The following is a description of a gene set: part of: Co-stimulation by CD28 CD28-mediated PI3K signaling plays a crucial role in augmenting T cell activation and survival. Phosphoinositide 3-kinases (PI3Ks) are lipid kinases that can be activated downstream of various receptors, including the T-cell receptor (TCR), co-stimulatory receptors like CD28, and cytokine or chemokine receptors. The role of PI3K signaling differs depending on the upstream receptor involved. CD28, specifically, contains a YMNM consensus motif in its cytoplasmic tail, which serves as a binding site for the p85 regulatory subunit of PI3K. <br>When CD28 is engaged, it promotes the recruitment of PI3K, complementing PI3K activation downstream of the TCR. This recruitment triggers the conversion of phosphatidylinositol (4,5)-bisphosphate (PIP2) to phosphatidylinositol (3,4,5)-trisphosphate (PIP3) at the plasma membrane, which serves as a docking site for multiple signaling proteins. Among these, the guanine nucleotide exchange factor VAV and the serine/threonine kinase AKT (also known as protein kinase B, PKB) are key mediators of CD28-induced costimulatory signals. PI3K activation through CD28 promotes cytokine transcription (e.g., IL-2), T cell survival via anti-apoptotic pathways, cell cycle progression, and metabolic changes necessary for T cell growth (Riha and Rudd. 2010, Miller et al. 2009, Han et al. 2012). Reactome Pathway: CD28 dependent PI3K/Akt signaling species: Homo sapiens, and this is the list of marker genes: PIK3R6, PIK3R1, FYN, RICTOR, PIK3R2, PDPK1, THEM4, M, PIK3CD, TRIB3, PRR5, PIK3R3, AKT2, MAP3K8, MTOR, AKT1, CD80, PIK3CG, CD86, CD28 (CD28 molecule), PIK3R5, N, MAPKAP1, MAP3K14, AKT3, PIK3CB, LCK, PIK3CA, MLST8